The following is a description of a gene set: Mouse Gene Set: GOMF_GLUTATHIONE_TRANSFERASE_ACTIVITY Catalysis of the reaction: R-X + glutathione = H-X + R-S-glutathione. R may be an aliphatic, aromatic or heterocyclic group; X may be a sulfate, nitrile or halide group. studied in species Mus musculus, and this is the list of marker genes: Alox5ap, Hpgds, Gstz1, Gstt4, Gsto2, Ptges, Gstt1, Gstm7, Gstm6, Gsto1, Gstm2, Gstm3, Mgst1, Gstm5, Gstp2, Gsta3, Lancl1, Gstm1, Gstk1, Mgst2, Mgst3, Gstt2, Gstm4, Gsta5, Gsta2, Gstp3, Gsta4, Gstt3, Gstp-ps, Gstp1, Ltc4s, Gsta13, Gsta1